The following is a description of a gene set: Human Gene Set: REACTOME_SUMOYLATION_OF_IMMUNE_RESPONSE_PROTEINS SUMOylation of immune response proteins studied in species Homo sapiens, and this is the list of marker genes: IKBKG, RELA, NFKBIA, UBE2I, TOPORS, NFKB2, PIAS4, SUMO3, PIAS3, IKBKE, EIF2AK2, SUMO1